Given this list of marker genes Rab11a, Tppp, Limk2, Clasp1 (CLIP associating protein 1), Cenpj, Pde4dip, Kpnb1, Tacc2 (transforming, acidic coiled-coil containing protein 2), Tacc3, Ezr, Dlg1, Cep120, Numa1, here is a description of the gene set: studied in species Mus musculus A process that is carried out at the cellular level which results in the assembly, arrangement of constituent parts, or disassembly of astral microtubules, any of the spindle microtubules that radiate in all directions from the spindle poles. Mouse Gene Set: GOBP_ASTRAL_MICROTUBULE_ORGANIZATION